The following is a description of a gene set: studied in species Homo sapiens Human Gene Set: MODULE_85 Genes in the cancer module 85., and this is the list of marker genes: DDR2, ROS1, FGFR2, KDR, IL2RG, TIE1, EFNB3, TGFBR1, IL10RA, RYK, MST1R, PDGFRA, EPHB6, FGFR3, FGFR1, EPHA7, EPHB2, IL13RA1, MPL, BMPR1B, LEPR, IL3RA, F3, ERBB2, EFNA4, KIT, EPHA2, ERBB4 (erb-b2 receptor tyrosine kinase 4), CSF2RB, IL7R, NRP1, EPHB4, ROR1, EPHA4, TEK, EPHB1, PTK7, IL4R, AXL, MERTK, ROR2, CSF2RA, IL2RB, PDGFRB, CSF3R, ACVR2A, MUSK, IL6R, IFNGR1, FGFR4, PDGFRL